Given this list of marker genes TMEM86B, CHPT1, AGMO, AGPS, PLA2G7, DHRS7B, PLA2G4C, PLA2G4A, LPCAT2, PEDS1, PAFAH1B1, FASN, PLA2G6, PEX7, GNPAT, FAR1, PXMP4, PLAAT3, PLA2G10, LIPE, SELENOI, NCEH1, here is a description of the gene set: studied in species Homo sapiens Human Gene Set: GOBP_GLYCEROL_ETHER_METABOLIC_PROCESS The chemical reactions and pathways involving glycerol ethers, any anhydride formed between two organic hydroxy compounds, one of which is glycerol.